Given this list of marker genes Fgfr1, Sptbn2 (NCBI Gene Id 20743), Ptprd, Lrrtm1, Cbln1, Ptk2b, Sipa1l1, Lrfn1 (leucine rich repeat and fibronectin type III domain containing 1), Cript, Prickle1, Lrrc4b, Arhgef9, Lats1, Abi3, Grid2, Lrrtm2 (NCBI Gene Id 107065), Abi3bp, Ptprs, Nlgn1, Wnt5a, Abl1, Nptxr, Lrfn4 (NCBI Gene Id 225875), Nrxn1, Il1rap, Prickle2, Gap43, Caskin1, here is a description of the gene set: Any process that modulates the frequency, rate or extent of postsynaptic specialization assembly, the aggregation, arrangement and bonding together of a set of components to form a postsynaptic specialization. species: Mus musculus Mouse Gene Set: GOBP_REGULATION_OF_POSTSYNAPTIC_SPECIALIZATION_ASSEMBLY